The following is a description of a gene set: studied in species Homo sapiens Decreased circulating follicle stimulating hormone concentration A reduction of the circulating level of follicle-stimulating hormone (FSH). Human Gene Set: HP_DECREASED_CIRCULATING_FOLLICLE_STIMULATING_HORMONE_CONCENTRATION, and this is the list of marker genes: SMO, NF2, LHX3, MANF, KISS1R, ANOS1, AKT1, PDGFB (platelet derived growth factor subunit B), CPE (NCBI Gene Id 1363), TERT, BAP1, TAC3, SMARCB1, ROBO1, KISS1, HESX1, SMARCE1, PROP1, OTX2, LGR4, TRAF7, POU1F1, LHX4, NHLH2, FEZF1 (FEZ family zinc finger 1), FSHB, PNPLA6, PIK3CA, SUFU, DMXL2, PRDM13, SEMA3A